Given this list of marker genes Fah, Lair1, Ctla4, Cd300c2, H2-Ab1, Hcst, C1qb, Lag3, Cd3e, Mcemp1, Tapbp, Bin2, Ncf1, Fcgr1 (Fc receptor, IgG, high affinity I), Stat1, Gimap4, Selplg, P2ry6, Lat2, Zbp1, Gimap3, Itgal, Ncf4, Il1b, Ccr5, Fermt3, Ptafr, Smdt1, Lilrb4a, Thbs3, Psme2, Gpr171, Myo1g, Plbd1, Rrad, H2-DMa, C1qc, H2-DMb1, Il21r, Il2rb, Tnfaip8l2, Prss30, Rasal3, Rnase6, Kcnj10, Tnfrsf4, Kbtbd4, Ccdc88b, Gpr35, H2-Q4, Ms4a7, Icos, Rac2, Nkg7, Xcl1, Dock2, Aif1, B2m, Tdrd9, Mxra8, Def6, Ccl4, Bcl2a1d (B cell leukemia/lymphoma 2 related protein A1d), H2-K1, Dipk1a, Pla2g2d, Cd40, Fxyd5, Slamf8, Tlr2, H2-DMb2, Arl5c, Spi1, Apol9b, Lst1, Skap1, Runx3, Lgals3, Pilra, Rgs10, Cxcl1 (NCBI Gene Id 14825), Hcls1, Fmnl1, Laptm5, Trem2 (NCBI Gene Id 83433), Plk3, Cd8b1, Cd4, Tbxas1, Coro1a, Man2b1, Anpep, Hoxb7, Rnf157, Klrd1, Lpcat2, Tigit, Cd3d, H2-D1, Pik3r6, Gpr84, Cyth4 (cytohesin 4), S1pr4, Sectm1a, Ctsb, Psme1, Cd33, Gpr132, Myo1f, Cd8a, Lcp2 (NCBI Gene Id 16822), Gpr137b, Ccr9, Tnfrsf23, Slc2a6, Pdcd1, Tlr12, Tyrobp, Antxr2, Cd2, Nfkbie, Mindy3, Alox5ap, Cd86, Adgrg5, Gng2, Cd6, Masp1, Entpd1, Micos13, Psmb10, Tgtp2, Ly6c1, Bst1, Lsp1, Hagh, Casp4 (caspase 4, apoptosis-related cysteine peptidase), Cd300a, Cxcl16, Klrb1b, H2-Aa, Ncf2, Itgax, Cd83, Lat, Nmi, Ly96, Plekho1, Dnase1l1, Bcl2a1b, Tmem140, Ly6a, Cd27, Trim43b, Susd3, Fcgr3, Sh2d2a, Rnf19b, Clec12a, Sting1, Cd3g, Prdx5, Zap70, Fcer1g, Ly86, Naaa, Serpina3g, Arhgap45, H2-Q7, Cxcl9, C1qa, Procr (NCBI Gene Id 98921), Bcl2a1a, Klrc1, Dok2, Spn, Ccl5, Cd74, P2ry14, Ctsw, Lyz2, Ccr8 (C-C motif chemokine receptor 8), Irf5, Tppp3, Irf8, Cd52, Sh2d1a, Lrrc25, Pld4, Slc15a3, Cd7, Gna15, Slamf6, Slc11a1, Apol9a, Ccl1, Traf3ip3 (TRAF3 interacting protein 3), Ltb, Clec4n, Metrnl, here is a description of the gene set: Metagene_25 is enriched in SKCM, which has a high response rate to anti-PD1 (Fig. 4D). The top-ranked genes in metagene_25 were Pdcd1, Cd8b1, and Cd3g (Fig. 5A), representative of CTL infiltration. Gene set enrichment analysis of genes in metagene_25 identified pathways of immunoregulatory interactions and antigen processing and presentation (Fig. 5, B and C). Metagene_25 also shows a positive correlation with improved patient survival and increased CD8+ T cell infiltration (Fig. 5, D and E). Mouse Gene Set: ZENG_GU_ICB_CONTROL_METAGENE_25_PRECICTIVE_ICB_RESPONSE Most patients with cancer are refractory to immune checkpoint blockade (ICB) therapy, and proper patient stratification remains an open question. Primary patient data suffer from high heterogeneity, low accessibility, and lack of proper controls. In contrast, syngeneic mouse tumor models enable controlled experiments with ICB treatments. Using transcriptomic and experimental variables from >700 ICB-treated/control syngeneic mouse tumors, developed a machine learning framework to model tumor immunity and identify factors influencing ICB response. Projected on human immunotherapy trial data, found that the model can predict clinical ICB response. further applied the model to predicting ICB-responsive/resistant cancer types in The Cancer Genome Atlas, which agreed well with existing clinical reports. studied in species Mus musculus from publication Zeng Z, Gu SS, Wong CJ, Yang L, Ouardaoui N, Li D, Zhang W, Brown M, Liu XS (PMID 36240281)